The following is a description of a gene set: Human Gene Set: GOCC_ER_TO_GOLGI_TRANSPORT_VESICLE_MEMBRANE studied in species Homo sapiens The lipid bilayer surrounding a vesicle transporting substances from the endoplasmic reticulum to the Golgi., and this is the list of marker genes: SEC16A, VTI1B, HLA-B, TMED7, SEC31A, CNIH3, SEC13, STX17, HLA-C, SEC24D, TMED2, HLA-DQA2, TMED10, SEC16B, STX5, SEC22B, MCFD2, B2M, SEC24C, GOSR2, VMA21, FOLR1, LMAN1, CD59, SEC24A, SEC31B, HLA-A, PDCD6, CD74, HLA-DQB2, KLHL12, SREBF1, CNIH1 (NCBI Gene Id 10175), HLA-DRA, HLA-DQB1, HLA-DPB1, SEC23B, SAR1A, SLC30A5, TGFA, VTI1A, HLA-DRB4, SEC24B, PEF1, CNIH2, USO1, HLA-F, HLA-DPA1, HLA-DRB5, HLA-E, SCAP, HLA-DRB1, HLA-H, SREBF2, AREG, HLA-DRB3, SAR1B, SEC23IP, GRIA1, CRYZL2P-SEC16B, HLA-DQA1, CIDEB, HLA-G, SEC23A